The following is a description of a gene set: from publication Anandasabapathy N, Victora GD, Meredith M, Feder R, Dong B, Kluger C, Yao K, Dustin ML, Nussenzweig MC, Steinman RM, Liu K (PMID 21788405) Genes up-regulated in brain microglia versus bone marrow monocytes. Human Gene Set: GSE29949_MICROGLIA_BRAIN_VS_MONOCYTE_BONE_MARROW_UP To understand the functional relationship between brain dendritic cells (brain DCs) and other myeloid cells, we compared the gene expression profile of m/chDCs to that of bone marrow monocytes, brain microglia and classical spleen CD8+ and CD8- DCs. In order to obtain enough brain DCs for mRNA extraction, we expanded brain DCs with in vivo Flt3L treatment before purification. species: Homo sapiens, and this is the list of marker genes: RRM2, SHANK2, GABRR1, MYH6, RANBP9, PTGER2, CYP2B7P, LGI1, GSTM3, MAPKBP1 (NCBI Gene Id 23005), EXTL1, GAB2, IGFBP2, CRYBB3, VIPR2, EIF5A, MXD1, EFNA1, CA6, CFP, NUP62, ORC1, HPCAL1 (hippocalcin like 1), FAM50B, MADD, SOX9, SRGAP2, TUBB4B, RABL3, KLC1, RHOBTB1, NPAS2, PLK2, MAGEB3, PPARG, OPRM1, TTLL12, CAND2, SALL1, RPL39L, GNRH1, MXRA5, ZNF169, FOXD1 (NCBI Gene Id 2297), CALCOCO1, TRADD, JCHAIN, NAGLU, EXT1, SEMG2, SMR3B, PTK7, MANBA, ATP2B4 (NCBI Gene Id 54594, ATPase plasma membrane Ca2+ transporting 4), CHST10, MAB21L1, SPINT2, LY86, HSD17B3, CTDP1, UNC93A, TRAM2, SGCG, CRHBP, EXPH5, YJU2, SDC2 (syndecan 2), UBL3, MDM2, NEBL, GYS2, WASF2, MYO16, DEFA5, LRP2, CD8B, NAA80, MAPT, ETV1, MPPED2, NR0B2, SLC12A1, SLC12A5, HTT, CAPNS1, APOB, IER2, BTC, HOXD8, CD80, CDKN1C, SFTPB, PINLYP, DEFA6, TNNI1, TNFSF9, PPIC, LINC00588, ALOX15B, NFASC, NFIL3, NEMF, ATP7B, TWF2, CLBA1, CSF1, NFATC3, CDH22, S100P, SCCPDH (NCBI Gene Id 51097), C5, NACC2, CTSL, GPR176, NDEL1, ABCD3, LINC00837, SLC19A1, KCNC1, CFTR, PNLIPRP1, SLC22A4, PPP1R16B, GNA15, NCF2, HSD11B1, USH2A, LEPR, MEOX2, PTGDR, HNRNPD, BATF, TBC1D1, KEAP1, AREG, NEUROD2, IL10RA (interleukin 10 receptor subunit alpha), TDO2, GPR183, HSF2BP, PDXK, SELL, EHMT2 (euchromatic histone lysine methyltransferase 2), INSL4, IL24, AGPAT1, TRIM28, HSD17B6, ACTC1, RSAD2, AGR2, PHKA1, STOML1, ZER1, PDIA2, TWIST1, KLRD1, FCER2 (Fc epsilon receptor II), PRKCA, RBM42, ZNF629, GFI1, GNAZ, HFE, ATP2A3, SRD5A2, SEMA3D, LILRB4, IMPDH1, KRT32, CHRNA6, EVI5, ZNF10, SLC7A5, CD47, SERPINB10, AFAP1, TMPRSS11D (NCBI Gene Id 9407), AKR1D1, SLC26A3, SERPINA7, HLX, GPR135, STARD3, ZNF711, ANXA1, PLCL1, TFEB, SDS, SOCS1, POM121L1P, LDOC1, GPX4, PRKAR2A, PAGE1, BAAT, ZBTB7A, RASSF9, P2RY2